The following is a description of a gene set: Any spliceosomal complex that forms during the splicing of a messenger RNA primary transcript to excise an intron; the series of U12-type spliceosomal complexes is involved in the splicing of the majority of introns that contain atypical AT-AC terminal dinucleotides, as well as other non-canonical introns. The entire splice site signal, not just the terminal dinucleotides, is involved in determining which spliceosome utilizes the site. species: Mus musculus Mouse Gene Set: GOCC_U12_TYPE_SPLICEOSOMAL_COMPLEX, and this is the list of marker genes: Rnpc3, Sf3b4, Zrsr2, Snrpert, Sf3b3, Snrpe, Snrpf, Zmat5, Snrpb, Phf5a, Snrnp35, Sf3b2, Snrpd2, Zcrb1, Ybx1, Pdcd7, Snrpg, Snrnp25, Rbm41, Snrnp48, Sf3b1, Snrpd1, Lsm7, Dhx15 (NCBI Gene Id 13204), Sf3b5, Snrpd3, Sf3b6